The following is a description of a gene set: Mouse Gene Set: GOBP_POSITIVE_REGULATION_OF_MUSCLE_ADAPTATION Any process that activates or increases the frequency, rate or extent of muscle adaptation. studied in species Mus musculus, and this is the list of marker genes: Ep300 (E1A binding protein p300), Mtor, Ppp3ca, Mymk, Trpc3, Foxo3, Myog, Aif1